The following is a description of a gene set: Any process that modulates the frequency, rate or extent of T-helper 1 cell differentiation. species: Mus musculus Mouse Gene Set: GOBP_REGULATION_OF_T_HELPER_1_CELL_DIFFERENTIATION, and this is the list of marker genes: Ccr2, Ascl2, Il27, Tnfsf4, Il4ra, Irf1, Ccl19, Hlx, Ripk2, Ccr7, Jak3, Anxa1, Socs5